The following is a description of a gene set: A toll-like receptor signaling pathway in which the MyD88 adaptor molecule mediates transduction of the signal. Toll-like receptors directly bind pattern motifs from a variety of microbial sources to initiate an innate immune response. Mouse Gene Set: GOBP_MYD88_DEPENDENT_TOLL_LIKE_RECEPTOR_SIGNALING_PATHWAY studied in species Mus musculus, and this is the list of marker genes: Irf7, Tlr9, Tnip1, Cd300lf, Reg3g, Cd300a, Ccdc134, Tlr2, Hspd1, Tlr4, Irf1, Myd88, Lrrfip2, Tlr13 (toll-like receptor 13), Tlr6